Given this list of marker genes BSPRY, WDR17, PEAK1, SGCZ, PREX2, GPX6, ST8SIA1, STK24, INPP4A, C6orf120, TOMM22, SPATA9, PLXNC1, SOCS3, TMED2, PATL1, FBXO42, IRF2, DYNC1LI2, KBTBD4, GABRB2, PPP1R12A, ANKRD13B, SUZ12, LRRFIP2, CLOCK, GPD2, TBC1D3, SETD7, TSHZ3, TAF4, CPEB1, USP9X, STYK1, KDR, TSPAN5, NR4A2, INTS13 (NCBI Gene Id 55726), LRP2, GDAP2, BMP8A (NCBI Gene Id 79787), ELOA, CDKN1B, RIN2, PJA2, KIF1B, CEP70, NUDT7, IPO7, CYBC1, NCK2, VCAN, DOCK9, NXPH1, TMEM212, HNRNPL, ARRDC3, CDK13, SRSF7, NRIP1, TNRC6B, DAZAP2, BRD1, KCNJ2, RPS3, F3, DCAF5, USP3, CACNB4, RANBP3, SERPINA9, GSKIP, CPEB3, GALNT13, NDUFAF4, CCDC148, VSTM4 (NCBI Gene Id 196740), TTC17 (NCBI Gene Id 55761), TBL1XR1, ZNF404, TRIM33, ADD3, KDSR, ATP11C, BAZ2B, MYLIP, BCDIN3D, RANBP3L, here is a description of the gene set: species: Homo sapiens from publication Chen Y, Wang X (PMID 31504780) Human Gene Set: MIR455_5P Genes predicted to be targets of miRBase v22 microRNA hsa-miR-455-5p in miRDB v6.0 with MirTarget v4 prediction scores > 80 (high confidence targets).